The following is a description of a gene set: Any process that stops, prevents, or reduces the frequency, rate or extent of fibrinolysis, an ongoing process that solubilizes fibrin, resulting in the removal of small blood clots. Human Gene Set: GOBP_NEGATIVE_REGULATION_OF_FIBRINOLYSIS studied in species Homo sapiens, and this is the list of marker genes: SERPINE1, PLG, HRG, SERPINF2, THBS1, PLAT, VTN, USF1, APOH, PLAU, THBD, F2